Given this list of marker genes IMP4, TREML2, BPI, EEF2K, UBE2E2, OPRL1, SEMA3D, RGS1, UGCG, RAB19, IL1R1, SPATA9, PNLDC1, BCAT1, ARL5B, PAK4, CASP12, PDE3B, ADGRL3, CYSLTR2, TRIM58, SPRY1, SMR3A, DDIT4, OR1D2, CALCRL, SLC4A11, GCLC, INMT, KLRG2, FXYD7, STAT4, CD3G, ASTL, CNTNAP3, PIN1P1, LHFPL4, TMPRSS11BNL, BLTP3A, HCRTR1, FAM199X, ENPP5, H2AC1, CHAC1, RABEP2 (NCBI Gene Id 79874), BAAT, SHISAL2B, MARCHF3, RSPO4, FBXW10, PLA2G6, CELSR3, TMEM82, BNC2, PCSK5, CCT5, TRIM71, ADGRG3, SLC19A3, CD27, CHODL (NCBI Gene Id 84535), TRAF1, EIF4A1, SASH1, BPIFB1, ADAM22, FSTL1, BCL2L14, AFDN, MINAR1, SNORA3A, TMEM70, SLC13A2, LCE3C, WDR19, IL2RG, LRP2, EN2, SUCO, CDC37, MIR17, CHIA, MRPS5, ST6GALNAC3, CNOT8, GSR, CCRL2 (NCBI Gene Id 9034), SORD, FTSJ1, MMP2, PLPPR3, SYCE2, BHLHA9, NOL11, CC2D2A (coiled-coil and C2 domain containing 2A), BMI1, SUSD1, XDH, SPARC, FCRL1, GTPBP10, MXI1, C1QA, FBXL19, FLYWCH1, VPS37D, SCIN, FAM131A, HOXA7, ANGPT1, ANKRD60, CD300LB, DOK2 (NCBI Gene Id 9046), PLD5, PRMT7, DRD5, WDR49, LYAR (Ly1 antibody reactive), KCNJ11, ACVR1C, CACHD1, TRIM6, IDE, PDK1, PLA2G4A, LARGE2, SATL1 (NCBI Gene Id 340562), BTBD19, AHI1, SMG6 (SMG6 nonsense mediated mRNA decay factor), MFNG, TTC4, DZIP1L, SLC9A2, CPN1, NEDD9, TMEM143 (NCBI Gene Id 55260, transmembrane protein 143), HES1, TPSB2, ATOX1, TMTC4, SYNCRIP, REP15, PDE4D, DENND4A, here is a description of the gene set: Genes down-regulated in NK cells versus B lymphocytes. studied in species Homo sapiens Murine Cytomegalovirus (MCMV) infection leads to early activation of various immune cells, including B and T lymphocytes, before the actual initiation of antigen-specific adaptive immunity. This activation is partly driven by innate cytokines, including type I interferon (IFN), which are induced early after infection. The objective of this study was to address the role of type I IFN in shaping early/innate B and T cell responses to a primary acute viral infection. In order to decipher the specific impact of IFN-I on cell subsets, we performed a genome-wide expression analysis on WT splenic B and CD8 T lymphocytes isolated from C57BL/6 mixed bone marrow chimera mice. This study complements series GSE39555, which focused on early responses of NK cells and of the two subsets of conventional dendritic cells. Human Gene Set: GSE45365_NK_CELL_VS_BCELL_DN